The following is a description of a gene set: Binding to a phosphatidylinositol 3-kinase, any enzyme that catalyzes the addition of a phosphate group to an inositol lipid at the 3' position of the inositol ring. Human Gene Set: GOMF_PHOSPHATIDYLINOSITOL_3_KINASE_BINDING studied in species Homo sapiens, and this is the list of marker genes: PTPN13, FAM83A, CBL, PIK3AP1, FYN, INSRR, CALM3, PIK3R2, IRS1, IRS4, NLRC3, FAM83B, INSR, IRS2 (insulin receptor substrate 2), BECN2, HCST, BECN1, IGF1R, CORO1A, FBXL2, GSN, CD2AP, LCK, PIK3R1, TYRO3, DAB2IP, JAK2